Given this list of marker genes Stat5b (NCBI Gene Id 20851), Pglyrp4, Il21, Mertk, Stat5a, Zfp683, Prdm1, Id2, Axl, Rabl3, Slamf6, Pbx1, Rasgrp1, Nfil3, Lgals9, Irf1, Pglyrp2, Gas6, Il15ra, Slamf1, Tusc2, Zbtb1, Hectd1, Sp3, Pglyrp1, Kctd9, Pglyrp3 (NCBI Gene Id 242100), Il15, Tyro3, Il11ra1, Gm36723, Kat7, Tcf3, Ptprc, Ikzf1, Tox, Flt3l, here is a description of the gene set: species: Mus musculus Mouse Gene Set: GOBP_NATURAL_KILLER_CELL_DIFFERENTIATION The process in which a relatively unspecialized cell acquires the specialized features of a natural killer cell.